Given this list of marker genes Trim27, Apc, Sfrp1, Hhex, Chordc1, Cdkn1b, Rtraf, Thy1, Mapk8ip1, Dnajc3, Smyd3, Plk1, Agt, Garem1, Dusp7, Cdk5rap1, Nf1, Psen1, Gstp-ps, Cox11, Qars1, Sfrp2 (secreted frizzled-related protein 2), Gstp3, Pkib, Adipoq, Trib1, Socs4, Gnaq, Hipk3, Sfrp5, Dnaja3, Rgs14, Mapt, Ggnbp2, Irs2, Nprl2, Cdk5rap3, Ptprh, Chmp6, Nr2f2, Heg1, Nf2, Nup62, Ceacam1, Macroh2a1, Ptpn1, Lrp6, Fem1a, Dab2ip, Dusp22, Itgb1bp1, Epha1, Inca1, Midn, Spry4, Uchl1, Hspb1, Dusp19, Fbxo7, Hyal2, Gadd45g (growth arrest and DNA-damage-inducible 45 gamma), Ptpn2, Rasip1, Slc8a1, Gadd45b, Vps25, Plec, Park7, Ppm1e, Akt1, Psen2, Tsg101, Men1, Pycard, Gba1 (glucosylceramidase beta 1), Prkar1a, Cav1, Zgpat, Cd300a, Tnfaip3, Mvp, Abl1, Ptk6, Spry2, Npm1, Akt1s1, Chp1, Cdkn2c, Mllt1, Ptpn6, Tigar, Gstp2 (glutathione S-transferase, pi 2), Sirt1, Trib3, Rb1, Lats2, Coro1c, Ptprc, Ptpn22, Kat2b, Rgs2, Wars1 (tryptophanyl-tRNA synthetase1), Cdkn1c, Prkrip1, Prkcd, Hmgcr, Mstn, Sh3bp5, Inpp5k (NCBI Gene Id 192772), Gadd45a, Acp4, Gckr, Prdx3 (peroxiredoxin 3), Spry1, Gprc5a, Myocd, Irak3, Dusp1, Ifng, Spred1, Pten, Wwtr1, Adar, Ppm1f, Blvra, Cblc, Socs5, Hexim2, Dusp3, Apoe, Taf7, Nppa, Lyn, Ubash3b, Ptprj, Wnk4, Pdcd4, Ajuba, Ppia, Wee2, Cdkn2a, Ptpro, Bmp2, Tfap4 (transcription factor AP4), Prkch, Gstp1, Tsc2, Cav3, Adarb1, Casp3 (caspase 3), Ptprb, Dnaja1, Dbndd2, Aida, Paqr3, Ptprt, Prkn, Lilrb4b, Gskip, Deptor, Pparg, Lats1, Shb (NCBI Gene Id 230126), Pkig, Prkca, Cdkn1a (cyclin dependent kinase inhibitor 1A), Cep85, Errfi1, Hnrnpu, Pkn1, Smpd1, Dtnbp1, Slc8a3, Fabp4 (NCBI Gene Id 16804), Zfyve28, Nolc1, Prkag2, Cep43, Pkia, Lilrb4a (leukocyte immunoglobulin-like receptor, subfamily B, member 4A), Il1b, Srcin1, Dusp10, Stk38, here is a description of the gene set: Mouse Gene Set: GOBP_NEGATIVE_REGULATION_OF_KINASE_ACTIVITY studied in species Mus musculus Any process that stops, prevents, or reduces the frequency, rate or extent of kinase activity, the catalysis of the transfer of a phosphate group, usually from ATP, to a substrate molecule.